The following is a description of a gene set: Gastrointestinal desmoid tumor Benign, slow-growing tumors without any metastatic potential. Despite their benign nature, they can damage nearby structures causing organ dysfunction. Histologically they resemble low-grade fibrosarcomas, but they are very locally aggressive and tend to recur even after complete resection. There is a tendency for recurrence in the setting of prior surgery and the most common localisation of these tumors is intraabdominal from smooth muscle cells of the instestine. Human Gene Set: HP_GASTROINTESTINAL_DESMOID_TUMOR studied in species Homo sapiens, and this is the list of marker genes: GREM1, SPRED1, APC, POT1, MUTYH, BMPR1A, CTNNB1